Given this list of marker genes UPF1, ETF1, GFM2, MTRF1L, JMJD4, APEH, EIF5A2, GSPT1, MRPL58, EIF5A (NCBI Gene Id 1984), SHFL, OGFOD1, MTRF1, EIF5AL1, ABCE1, HEMK1, MTRFR, GSPT2, here is a description of the gene set: The process resulting in the release of a polypeptide chain from the ribosome, usually in response to a termination codon (UAA, UAG, or UGA in the universal genetic code). species: Homo sapiens Human Gene Set: GOBP_TRANSLATIONAL_TERMINATION